Given this list of marker genes Slc15a1, Slc25a40, Slc13a3, Slc15a2, Abcc4, Abcc1, Slc25a39, Gja1, Abcc5, here is a description of the gene set: species: Mus musculus Mouse Gene Set: GOMF_TRIPEPTIDE_TRANSMEMBRANE_TRANSPORTER_ACTIVITY Enables the transfer of a tripeptide, a compound containing three amino acids linked together by peptide bonds, from one side of a membrane to the other.